The following is a description of a gene set: part of: RHO GTPase Effectors This event has been computationally inferred from an event that has been demonstrated in another species.<p>The inference is based on the homology mapping from PANTHER. Briefly, reactions for which all involved PhysicalEntities (in input, output and catalyst) have a mapped orthologue/paralogue (for complexes at least 75% of components must have a mapping) are inferred to the other species. Reactome Pathway: RHO GTPases activate PAKs electronically inferred by orthology from the curated human pathway species: Mus musculus, and this is the list of marker genes: Myl9, Pak3, Nf2, Myh10, Calm1, Myl6, Myh14, Cdc42